The following is a description of a gene set: Mouse Gene Set: GOBP_BASIC_AMINO_ACID_TRANSPORT studied in species Mus musculus The directed movement of basic amino acids, amino acids with a pH above 7, into, out of or within a cell, or between cells, by means of some agent such as a transporter or pore., and this is the list of marker genes: Slc15a4, Slc38a3, Slc7a3, Slc7a1, Slc25a29, Slc25a15, Slc22a2, Slc47a1 (solute carrier family 47, member 1), Slc11a1, Slc7a5, Cln3, Slc25a2, Slc38a9, Slc7a6, Slc3a2, Slc7a7, Slc38a4, Slc66a1, Slc7a2, Slc7a9